Given this list of marker genes CFH, TCF4 (transcription factor 4), MPV17, AHCY (NCBI Gene Id 191), RINT1, SEMA4D, SOS2, EFL1, MTTP, HADH, HLA-DQB1, PLOD3, NR1H4, F5, TRMU, PET100, HMGCL, CYP7B1, GGCX (gamma-glutamyl carboxylase), GPR35, MICOS13, GFI1B, THBS2, F9, ACAD9, PRF1, OTC, SLC25A13, MCFD2, COG8, F2, FAH, ALG12, NBAS, AGA, SLC37A4, PGM1, HLA-DQA1, PMM2, F7, F10, ADK, CLPB, HELLPAR, VKORC1, CD46, LMAN1, NGLY1, CFI, SLC30A10, GNE, MST1, PSMB9, AMACR, AKR1D1, here is a description of the gene set: Abnormality of prothrombin Human Gene Set: HP_ABNORMALITY_OF_PROTHROMBIN studied in species Homo sapiens An anomaly of clotting factor II, which is known as prothrombin, a vitamin K-dependent proenzyme that functions in the blood coagulation cascade.